The following is a description of a gene set: Mouse Gene Set: GOBP_NEUTROPHIL_MEDIATED_KILLING_OF_GRAM_NEGATIVE_BACTERIUM studied in species Mus musculus The directed killing of a gram-negative bacterium by a neutrophil., and this is the list of marker genes: F2rl1, Tusc2, Trem1, F2, Cxcl5, Dao, Elane, Trem3